The following is a description of a gene set: Reactome Pathway: Cellular response to starvation species: Mus musculus electronically inferred by orthology from the curated human pathway This event has been computationally inferred from an event that has been demonstrated in another species.<p>The inference is based on the homology mapping from PANTHER. Briefly, reactions for which all involved PhysicalEntities (in input, output and catalyst) have a mapped orthologue/paralogue (for complexes at least 75% of components must have a mapping) are inferred to the other species. part of: Cellular responses to stress, and this is the list of marker genes: Bmt2, Atp6v1e2, Kics2, Seh1l, Rraga, Sesn2, Lamtor2, Rheb (NCBI Gene Id 19744), Fnip2, Lamtor4, Atp6v0e2, Atp6v1f, Wdr24, Tcirg1, Castor1, Atp6v1c2 (ATPase, H+ transporting, lysosomal V1 subunit C2), Wdr59, Lamtor1 (late endosomal/lysosomal adaptor, MAPK and MTOR activator 1), Atp6v1g3, Fnip1, Castor2, Atp6v0c, Atp6v0d1, Lamtor5, Flcn, Atp6v1a, Atp6v1g2, Atp6v0e, Szt2, Atp6v1d, Rragc